The following is a description of a gene set: Proper control of the G(1)/S checkpoint is essential for normal proliferation. The activity of p53 must be kept at a very low level under unstressed conditions to allow growth. Here we provide evidence supporting a crucial role for TopBP1 in actively repressing p53. Depletion of TopBP1 upregulates p53 target genes involved in cell cycle arrest and apoptosis and enhances DNA damage-induced apoptosis. The regulation is mediated by an interaction between the seventh and eighth BRCT domains of TopBP1 and the DNA-binding domain of p53, leading to inhibition of p53 promoter binding activity. Importantly, TopBP1 overexpression is found in 46 of 79 primary breast cancer tissues and is associated with high tumor grade and shorter patient survival time. Overexpression of TopBP1 to a level comparable to that seen in breast tumors leads to inhibition of p53 target gene expression and DNA damage-induced apoptosis and G(1) arrest. Thus, a physiological level of TopBP1 is essential for normal G(1)/S transition, but a pathological level of TopBP1 in cancer may perturb p53 function and contribute to an aggressive tumor behavior. studied in species Homo sapiens Genes up-regulated in U2OS cells (osteosarcoma) upon knockdown of TOPBP1. from publication Liu K, Bellam N, Lin HY, Wang B, Stockard CR, Grizzle WE, Lin WC (PMID 19289498) Human Gene Set: LIU_TOPBP1_TARGETS, and this is the list of marker genes: AQP3, E2F5, HIC1, RECQL5, TP73, PAX5, ERBB4, COQ8A, MPZL2, SMR3B, TP53INP1, IGFBP3, MDM2